Given this list of marker genes ACSL3, HTR2C, CHP1, CAPN2, PDGFA, MIR30C1, LPIN1, XBP1, RAB38, ADGRF5, FABP3 (fatty acid binding protein 3), PDGFB, NR1H4, ABCA2, SCP2, LPCAT1, HTR2A, HTR2B, IDH1, here is a description of the gene set: studied in species Homo sapiens Human Gene Set: GOBP_REGULATION_OF_PHOSPHOLIPID_BIOSYNTHETIC_PROCESS Any process that modulates the frequency, rate or extent of the chemical reactions and pathways resulting in the formation of phospholipids.